The following is a description of a gene set: Human Gene Set: GOMF_G_PROTEIN_COUPLED_RECEPTOR_BINDING Binding to a G protein-coupled receptor. studied in species Homo sapiens, and this is the list of marker genes: P2RY1, CXCL10, DEFB4A, CCKBR, DNAJC14, CXCL16, NEDD4, ADORA1, HSPA8, PENK, CCL5, YARS1, ITGB4, GNAI3, ADRB1, GIP, GPHB5, EDN1, MLN, WNT1, WNT16, CNRIP1, CCL4L2, NPY, GPHA2, HBA2, S1PR2, OXT, ARMCX5-GPRASP2, PPY, LRP6, CXCL3, RTP1, CCL14, RSPO1, TULP3, ARHGEF12, CCL21 (C-C motif chemokine ligand 21), CRH, GNA14 (NCBI Gene Id 9630), WNT3, CKLF, SCT, CCL25, CCL11, DVL2, CCL18, JAK2, GPRC5B, PHB1, EDN3, ARAP1, PTH, TSNAX, CXCL1, S1PR1, ADCYAP1, DLG4, WNT3A, GHRH (NCBI Gene Id 2691), CXCL9, CAV2, TAC3, CCL26, CCL20, CCL13, XCL2, DEFB110, ADM, FZD1, GNAO1, RALA, HOMER2, SPX, CXCL5, GPRASP2 (NCBI Gene Id 114928), CXCL12, C1QBP (NCBI Gene Id 708), PTGER1, CCL1, RTP4, NECAB2, RSPO3, DEFB130B, CCL15, TFF2, SAG, BBS1 (NCBI Gene Id 79702), WNT2B, ADRB3, NARS1, PACRG, USP4, NPB, RPGRIP1L, FPR1 (NCBI Gene Id 2357), S100A14, CXCL6, GNAS, CORT, TAFA5, USP20, CXCL13, IL2, TMED2, DEFB130A, FLNA, GCG, NMB, CXCL2, DVL3, DEFB1, RNF43, POMC, GNAQ, HBA1, CCL27, PDYN, NHERF1, ADRA2C, PF4V1, DNAJA1, GNAL, XCL1, CALM3, TAC4, CALCA, CCL7, ARHGEF11, DEFB103A, RAPGEF2, PYY3, APLP1, AGT, PICK1, BICD1, CCL8, ASIP, SHANK1, RLN3, PRKN, AKAP5, WNT10A, ADORA2A, CNIH4, GNA11, CCL24, WNT10B, GNA12 (NCBI Gene Id 654140), DEFB109B, NTS, CCL4, GNAI2, C3, FZD7, HCRT, DEFB106B, STAT1, GNAT1, UCHL1, MRAP, CLIC6, ACE, PNOC, CCL28, ANAPC11, ARRB2, MARCO, APELA, FYN, NDP, CCL2, CCL3L3, WNT7B, DEFB133, RTP2, P2RY2, UTS2B, AVPR1A, APLN, REEP2, ZNRF3, ITCH, SNX5, HSPA1A, AVP, RTP5, UCN3, TUB, STAT3, CXCL11, AGRP, CCDC88C, PTCH1, PMCH, EDN2, KISS1 (KiSS-1 metastasis suppressor), CCL17, MYOC, PALM, FCN1, C5, GRIA1, CCL22, NPPA, GNAZ, GHRL, WNT4, MSMP, NPFFR2, NPW, PRNP, CCRL2, PDE4D, RYK, RTP3, PROK2, DEFB106A, CX3CR1, GRM5, CX3CL1, ZBTB16, PDCD6IP, PF4, NES, WNT11, GNAT2, NMU, WNT6, WNT7A, GNA13, BAMBI, PTCH2, MRAP2, NHERF2, ADA2, NPFF, PSMC5, WNT9B, DVL1, CALCB, MAGI3, WNT5A, DEFB114, REEP1, ARR3, GNAI1, WNT2, HSPA1B (NCBI Gene Id 3304), UCN, HOMER1, JAK1, DEFB103B, TAC1, PYY, VIP, MAGI2, CTHRC1, FEM1A, PPBP, INSL5, HOMER3, STUB1, CREB3, GAL, WNT9A, GRK3, CCL23, BDKRB2, ARHGEF1, WNT8B, VPS35, USP33, UCN2, CXCL14, SAA1, PMCHL2, WNT8A, WNT5B, GPR15LG, SFRP1, SDCBP, GNA15, ARRB1, CCL19, APP (NCBI Gene Id 351), QRFP, PRLH, AGTR1, EDNRB, ARRDC3, CCL3, GNAT3, CCL16, CCR2, CXCL8, PPP1R9B, GRK2, ADRA2A